The following is a description of a gene set: Paralysis (complete loss of muscle function) in the arm, leg, and in some cases the face on one side of the body. Hemiplegia species: Homo sapiens Human Gene Set: HP_HEMIPLEGIA, and this is the list of marker genes: PRRT2, PRTN3, PTPN22, PAH, SPP1, SCN1A, TBC1D24, COL4A1, KRAS, SUOX, IRAK1, COQ2, FUCA1, ADSL, SAT1, ATP1A3, GNAQ, GNB1, DOCK8, SLC1A3 (NCBI Gene Id 6507), SCN5A, CTLA4, ARX, PRF1, MT-CYB, SNORD118, STAT4, COL4A2, GALC, ATP1A2, FGFR1, HLA-DPA1, ADA2, SMARCAL1, CTC1, NPPA, CACNA1A, HLA-DPB1, NOTCH3